Given this list of marker genes ASPSCR1, PTPN9, AXL, DFFB, GREM2, MRPL13, IL15, SLC7A5, NSDHL, THAP12, JUN, B4GALNT2, TWIST1, NMRK1, NCOA2, HAL, CDKN2A (cyclin dependent kinase inhibitor 2A), TRIP12, RAD50, CLCN5, GGH, MAP3K1, COL9A1, SHKBP1, MPHOSPH9, IGF2BP1, CDK14, RAB12, HTR5A, ZFP37, TMEM109, PIK3C2G, NR4A2, ARHGEF25, ITGB5, NFATC2, NELFA, PITPNB, GALNT6, CYBB, HOXA2, DCN, SELENOW, FGF1, MAPK13, PITPNC1, C5orf15, MAP7D1, PLAUR, HMOX2, NYNRIN, MIPOL1, NDUFA1, AAAS, CASP6, TAL1, GPR132, IL2RB, STK24, COL14A1, SHBG, SIAH2, SBDS, CYP21A1P, ATOH7, FBXL12, ANXA7, SNTA1, RPL35, HAS2, AIP, TRPC1, MOS, GPHN, NMT1, ECM1 (NCBI Gene Id 1893), HDC, TSPAN4, RNF19B, TPPP3, NOLC1, CSN3, CIAPIN1, ZNF777, STMN2, POU3F1, ASNS, CWF19L1, ALDH18A1, ACR, TBX15, RDH5, BRWD3, NSG2, DNAJA2, TINF2, ACVR1B, LRG1, ERCC4, ARF4, CRK (CRK proto-oncogene, adaptor protein), B3GALT2, PREPL, PRKCA, TNFRSF9, POLG2, CREBBP, ADCY9, CD86, GNAZ, IL1R2, ZBTB2, NPTX1, HES5, FNBP1, CAB39L, DHRSX, RGR, XIAP, PTGER2, PTGDR2, TRDMT1, INO80E, MAOA, HES1, TRAPPC3, FMR1NB, DDAH2, PTPRN2, ABT1, TMEM199, BDKRB1, SRPRA, LY9, BHLHE40, GDF5, VAPB, PTGFR, DSPP, GFRA2, LIMA1 (NCBI Gene Id 51474), BSN, CCNB1IP1, ICAM5, NUBP1, MMP24, ZKSCAN5, ANKH, EN1, HOXA11-AS, RAG2, TBCEL, CPQ, VWA7, SEC22B, CXCR5, MIS18A, RYR3, WDFY2, ITGB7, JAG2 (jagged canonical Notch ligand 2), AP3M1, TSR3, SLC66A2, CRP, FAM241A, DDX19A, ZRANB1, ZNF292, SCN3A, CCNDBP1, SURF1, CASP12, PAM, CCR7, ST3GAL5, SDSL, HSPBP1, HLA-DOB (NCBI Gene Id 3112), ZFP14, GNPTAB, PHPT1, MAEA, PTPN13, PNP, E2F5, CLEC11A, TMEM106C, ENTPD4, KCNJ3, FLOT2, ADAM22, MEIS3, OPRD1, SELENOF, CDON, TBX3, WWTR1, TNS2, BCHE, here is a description of the gene set: species: Homo sapiens Genes up-regulated in double positive thymocytes: wildtype versus over-expressing HDAC7 fused with VP16. Abstract of publicaton: CD4/CD8 double-positive (DP) thymocytes express the transcriptional repressor Histone Deacetylase 7 (HDAC7), a class IIa HDAC that is exported from the cell nucleus after T cell receptor (TCR) engagement. Through signal-dependent nuclear export, class IIa HDACs such as HDAC7 mediate signal-dependent changes in gene expression that are important to developmental fate decisions in multiple tissues. We report that HDAC7 is exported from the cell nucleus during positive selection in thymocytes, and regulates genes mediating the coupling between TCR engagement and downstream events that determine cell survival. Thymocytes lacking HDAC7 are inefficiently positively selected due to a severely shortened lifespan and exhibit a truncated repertoire of TCR Jalpha segments. The expression of multiple important mediators and modulators of the response to TCR engagement is altered in HDAC7-deficient thymocytes, resulting in increased tonic MAP kinase activity that contributes to the observed loss of viability. Remarkably, the activity of Protein Kinase D, the kinase that mediates nuclear export of HDAC7 in response to TCR signaling, is also increased in HDAC7-deficient thymocytes, suggesting that HDAC7 nuclear export governs a self-sustaining auto-excitatory loop. These experiments add to the understanding of the life/death decision in thymic T cell development, define a novel function for class IIa HDACs, and point to a novel feed-forward mechanism whereby these molecules regulate their own state and mediate stable developmental transitions. Title of manuscript: Nuclear Export of Histone Deacetylase 7 During Thymic Selection Mediates Immune Self-tolerance. abstract of manuscript: Histone Deacetylase 7 (HDAC7) is a TCR signal-dependent regulator of differentiation that is highly expressed in CD4/CD8 double-positive (DP) thymocytes. Here we examine the effect of blocking TCR-dependent nuclear export of HDAC7 during thymic selection, through expression of a signal-resistant mutant of HDAC7 (HDAC7-delta-P) in thymocytes. We find that HDAC7-delta-P Transgenic thymocytes exhibit a profound block in negative thymic selection, but can still undergo positive selection, resulting in the escape of autoreactive T cells into the periphery. Gene expression profiling reveals a comprehensive suppression of the negative selection-associated gene expression program in DP thymocytes, associated with a defect in the activation of MAP kinase pathways by TCR signals. The consequence of this block in vivo is a lethal autoimmune syndrome involving the exocrine pancreas and other abdominal organs. These experiments establish a novel molecular model of autoimmunity and cast new light on the relationship between thymic selection and immune self-tolerance. Goal of Microarray experiment: We did these experiments to determine how alteration of the function of HDAC7, a site-specific and signal-dependent repressor of transcription, changes gene expression in CD4/CD8 DP thymocytes. Human Gene Set: GSE26488_WT_VS_VP16_TRANSGENIC_HDAC7_KO_DOUBLE_POSITIVE_THYMOCYTE_UP from publication Kasler HG, Young BD, Mottet D, Lim HW, Collins AM, Olson EN, Verdin E (PMID 21398603)